The following is a description of a gene set: Mouse Gene Set: GOBP_DETECTION_OF_BIOTIC_STIMULUS species: Mus musculus The series of events in which a biotic stimulus, one caused or produced by a living organism, is received and converted into a molecular signal., and this is the list of marker genes: Parg, Nlrp3, Pglyrp4, Smo, Tlr9, Itgav, Crtam, Cd209b, Tlr1 (NCBI Gene Id 21897), Tlr6, Nod2, Lbp, Atf2, Ssc5d, Srpx, Tspo, Clec4n, Pglyrp1, Pglyrp2, Nod1, Clec7a, Pglyrp3, Naip5, Nr4a1, Naip6, Ly96, Naip1, Scarb1, Naip2, Nlrc4, Casp4, Tlr2, Trem2, Dach1, Cdhr2, Tlr4, Fap, Pak1